The following is a description of a gene set: from publication McMurray HR, Sampson ER, Compitello G, Kinsey C, Newman L, Smith B, Chen SR, Klebanov L, Salzman P, Yakovlev A, Land H (PMID 18500333) studied in species Mus musculus Up-regulated 'cooperation response genes': responded synergystically to the combination of mutant TP53 and HRAS in YAMC cells (colon). Understanding the molecular underpinnings of cancer is of critical importance to the development of targeted intervention strategies. Identification of such targets, however, is notoriously difficult and unpredictable. Malignant cell transformation requires the cooperation of a few oncogenic mutations that cause substantial reorganization of many cell features and induce complex changes in gene expression patterns. Genes critical to this multifaceted cellular phenotype have therefore only been identified after signalling pathway analysis or on an ad hoc basis. Our observations that cell transformation by cooperating oncogenic lesions depends on synergistic modulation of downstream signalling circuitry suggest that malignant transformation is a highly cooperative process, involving synergy at multiple levels of regulation, including gene expression. Here we show that a large proportion of genes controlled synergistically by loss-of-function p53 and Ras activation are critical to the malignant state of murine and human colon cells. Notably, 14 out of 24 'cooperation response genes' were found to contribute to tumour formation in gene perturbation experiments. In contrast, only 1 in 14 perturbations of the genes responding in a non-synergistic manner had a similar effect. Synergistic control of gene expression by oncogenic mutations thus emerges as an underlying key to malignancy, and provides an attractive rationale for identifying intervention targets in gene networks downstream of oncogenic gain- and loss-of-function mutations. Mouse Gene Set: MCMURRAY_TP53_HRAS_COOPERATION_RESPONSE_UP, and this is the list of marker genes: Plac8, Slc14a1, Eno3, Tnnt2, Ccl9, Sod3, Oaf, Arap3, Sema7a, Ank, F2rl1, Kctd15, Parvb, Hmga2, Pla2g7, Fgf7, Cxcl15, Ankrd1, Gpr149, Cxcl1, Hbegf, Chst1, Cadm1, Hmga1, Mrpl15, Rgs2, Serpinb2, Sms